The following is a description of a gene set: Oxidoreductases. Human Gene Set: MODULE_373 species: Homo sapiens, and this is the list of marker genes: GSTZ1, DDC, AOC1, DBT, ALDH3A2, MAOA, GOT2, HPD, GOT1, AOX1, ADH1B, ALDH3B1, ALDH1A1, MAOB, ALDH3A1, AOC3 (amine oxidase copper containing 3), ADH7, ADH4, ADH1A, ALDH3B2, ADH1C, HGD